The following is a description of a gene set: Paralysis of voluntary muscles means loss of contraction due to interruption of one or more motor pathways from the brain to the muscle fibers. Although the word paralysis is often used interchangeably to mean either complete or partial loss of muscle strength, it is preferable to use paralysis or plegia for complete or severe loss of muscle strength, and paresis for partial or slight loss. Motor paralysis results from deficits of the upper motor neurons (corticospinal, corticobulbar, or subcorticospinal). Motor paralysis is often accompanied by an impairment in the facility of movement. Human Gene Set: HP_PARALYSIS Paralysis studied in species Homo sapiens, and this is the list of marker genes: BCHE, TNFSF11, SH3TC2, SDHA, TGM6, TAF15, DAO, ADCY6, KCNJ18, POLA1, GLE1, ABCB6, HMBS, ALDH18A1, PON2, SQSTM1, DCTN1, GABRA3, TRPM7, TRIM2, SLC2A1, SLC25A11, KCNJ5, TREM2, MTRFR, ZNF699, DKK1, ERBB4, EPAS1, NEK1 (NCBI Gene Id 51037), CPOX, CHCHD10, MYH14, LONP1, PRX, TBK1, TNNC2, HTRA1, CFAP410, SLC52A3, HNRNPA1, CHMP2B (NCBI Gene Id 7877), RILPL1, SEC31A, CAMK2B, NF1 (neurofibromin 1), MFN2, SDHD, SDHB, PRRT2, CYP27A1 (NCBI Gene Id 1593), SCN4A, ALOXE3, ANG (angiogenin), CCNF, SLC5A7 (solute carrier family 5 member 7), JAG1 (jagged canonical Notch ligand 1), PPARGC1A, GIPC1, FGFR1, ANXA11, PON1, KCNJ2, CD59, CACNA1A, GM2A, VHL, GDAP1, KIF1B, MYCN, ALS2, MAX, SBF2, NFU1, NOTCH2NLC (NCBI Gene Id 101060315), FHL1, TMEM43, PMP22, CLCN7, DLST, RET, SRPX2, ATXN2, MEGF10, DST, PDCD10, BAG3, SLC12A3, NONO, SCN1A, ATXN3, GLT8D1, NOTCH3 (notch receptor 3), CA2, MLXIPL, HSPB8, PPOX, ACTB, SDHC, RARS1, MDH2, TRPV4, VCP, OPTN, TRAPPC12, SETBP1, CACNA1S, COL4A1, PON3, ALAD, SCO2, CLCNKB, B4GALNT1, LMNA, FH, FIG4, FUS, CNTNAP1, POLR1A, SYNE1, MORC2, REEP1, HSPB1, MATR3, SLC25A19, PFN1, ATP1A2, SDHAF2 (succinate dehydrogenase complex assembly factor 2), ALOX12B, ZFYVE26, KRAS, UBQLN2, GAA, TPI1, KCNE3, HAAO, NEFH, UNC13A, LRP12, DNMT3A, POLG, IGHMBP2, TCIRG1, SOD1, FAH, CDH23, HK1, PRPH, PI4KA, EMD, TARDBP, ADGRG1, VAPB, ELN, NUS1 (NUS1 dehydrodolichyl diphosphate synthase subunit), SYNE2, TMEM127, EEF2, GBA1